Given this list of marker genes Sirt6, Gsto1, Stk39, Kcnq1, Fmr1 (fragile X messenger ribonucleoprotein 1), 1810037I17Rik, Hamp2, Grb10, Trdn, Rhoq (ras homolog family member Q), Calm2, Slc30a1, Mmp9, Ppif, Cers1, Akt1, Pcsk9 (proprotein convertase subtilisin/kexin type 9), Iscu, Dysf, Gstm7, Pea15a, Cacna1f, Fcrl5, Vdac1, Mcub, Calm3, Oaz2, Kcne3, Cbarp, Ucp2, Oxsr1, Gopc, Oaz3, Atp1a2, Gnb5, Kcne2 (NCBI Gene Id 69143), Ubr3, Ppp3cb, Actn2, Akt2, Ahr, Smim6, Prkca, Osr1, Ahi1, Casq2, Ostn, Pid1, Irs2 (NCBI Gene Id 384783), Epo, Nedd4, Kcnab1, Tlr9, Cav1, Gsk3a, Rgs4, Slc26a5, Sumo1, Ywhaq, Crbn, Rem1, Pkd2, Esr1, Prkcb, Acacb, Kcne5, Ntsr1, Ubqln1, Nos1, Ace, Kcnrg, Ppp3r1, Calm1, Sln, Kcne1, Lep, Mtor (NCBI Gene Id 80612), Rgs2, Pln (NCBI Gene Id 18821), Kcnh2, Prkce (protein kinase C, epsilon), Slc43a1, Commd1, Fabp5, Tgfb2, Grp, Ywhae, Stxbp3, Upk3b, Fkbp1b, Zfas1, Agrn, Bcl2 (B cell leukemia/lymphoma 2), Ppp3cc, Cttnbp2nl, Cav3, Nherf1, Bin1 (NCBI Gene Id 30948), Sestd1, Arl6ip5, Mrln, Tmbim6, Hamp, Ppp3ca, Sri, Camk2d, Ppp3r2, Tgfb1, Ptger3 (NCBI Gene Id 19218, prostaglandin E receptor 3 (subtype EP3)), Kel, Pik3c2a (NCBI Gene Id 18704), Inpp5k (inositol polyphosphate 5-phosphatase K), Tnf (tumor necrosis factor), Sh2b2 (NCBI Gene Id 54699), Gpr35, Appl2, Enpp1, Drd4, Ank3, Slc43a2, Myc, Fbxo11, Thbs1, Drd2, Atp7a, Grk2, Nedd4l, Oaz1, Il1b, here is a description of the gene set: Any process that stops, prevents, or reduces the frequency, rate or extent of the directed movement of a solute from one side of a membrane to the other. species: Mus musculus Mouse Gene Set: GOBP_NEGATIVE_REGULATION_OF_TRANSMEMBRANE_TRANSPORT